The following is a description of a gene set: Mouse Gene Set: BOYLAN_MULTIPLE_MYELOMA_C_CLUSTER_UP Multiple myeloma is an incurable plasma cell malignancy for which existing animal models are limited. We have previously shown that the targeted expression of the transgenes c-Myc and Bcl-X(L) in murine plasma cells produces malignancy that displays features of human myeloma, such as localization of tumor cells to the bone marrow and lytic bone lesions. We have isolated and characterized in vitro cultures and adoptive transfers of tumors from Bcl-xl/Myc transgenic mice. Tumors have a plasmablastic morphology and variable expression of CD138, CD45, CD38, and CD19. Spectral karyotyping analysis of metaphase chromosomes from primary tumor cell cultures shows that the Bcl-xl/Myc tumors contain a variety of chromosomal abnormalities, including trisomies, translocations, and deletions. The most frequently aberrant chromosomes are 12 and 16. Three sites for recurring translocations were also identified on chromosomes 4D, 12F, and 16C. Gene expression profiling was used to identify differences in gene expression between tumor cells and normal plasma cells (NPC) and to cluster the tumors into two groups (tumor groups C and D), with distinct gene expression profiles. Four hundred and ninety-five genes were significantly different between both tumor groups and NPCs, whereas genes were uniquely different from NPCs in tumor group C and genes were uniquely different from NPCs in tumor group D. Similar to human myeloma, the cyclin D genes are differentially dysregulated in the mouse tumor groups. These data suggest the Bcl-xl/Myc tumors are similar to a subset of plasmablastic human myelomas and provide insight into the specific genes and pathways underlying the human disease. Genes from cluster 1: up-regulated in group C of tumors arising from overexpression of BCL2L1 and MYC in plasma cells. studied in species Mus musculus from publication Boylan KL, Gosse MA, Staggs SE, Janz S, Grindle S, Kansas GS, Van Ness BG (PMID 17483317), and this is the list of marker genes: Ssx2ip, Nfya, Adra2a, Tpm3, Eps8, Tifa, Skp2, Ppm1f, B3gnt8, Gabpb1, Gm36401, Mtor, Marcksl1, Foxm1, Zfpm1, Uhrf1 (NCBI Gene Id 18140), Hnrnpd, Pomt1, Slc43a3, Apc, Reln, Foxp4, Kras, Gas2l3, Dpp4, Stom, Cad, Rbm14, Mllt1, Cstf1, Niban3, Tyms, Pter, Nrarp, Rag1, Ptgr1, Sapcd1